Given this list of marker genes Slc38a5, Slc1a5, Slc38a2, Slc38a1, Slc38a3, here is a description of the gene set: species: Mus musculus The directed movement of L-glutamine from outside of a cell, across the plasma membrane and into the cytosol. Mouse Gene Set: GOBP_L_GLUTAMINE_IMPORT_ACROSS_PLASMA_MEMBRANE